Given this list of marker genes PDPN, NR2F2, PROX1, BMPR2, TIE1, ACVR2B, ACVRL1, SOX18, here is a description of the gene set: Human Gene Set: GOBP_LYMPHATIC_ENDOTHELIAL_CELL_DIFFERENTIATION species: Homo sapiens The process in which a venous blood vessel endothelial cell acquires specialized features of a lymphatic vessel endothelial cell, a thin flattened cell that lines the inside surfaces of lymph vessels.